The following is a description of a gene set: Human Gene Set: GOBP_SKELETAL_MUSCLE_TISSUE_REGENERATION species: Homo sapiens The regrowth of skeletal muscle tissue to repair injured or damaged muscle fibers in the postnatal stage., and this is the list of marker genes: CD9, MYMX, SPAAR, KPNA1, LARGE1, PAX7, MCUB, COL6A1, PTGFRN, CAPN3, BIN3, P2RX5, GJD4, PPARD, BCL9, MYMK, EYS, MYOD1, WNT7A, TARBP2, EZH2, FKRP, IGF1, CFLAR, HOPX, PPP3CA (protein phosphatase 3 catalytic subunit alpha), TMEM182, DAG1, MYOZ1, SELENON, B4GALNT2, HDGFL2, MYF6, SOX15, AKIRIN1, CD81, IFRD1, WNT10B, XIRP1, GPX1, FZD7, ANXA1, MSTN, KLF5, NACA